The following is a description of a gene set: Any process that stops, prevents, or reduces the frequency, rate or extent of the chemical reactions and pathways involving fatty acids. Human Gene Set: GOBP_NEGATIVE_REGULATION_OF_FATTY_ACID_METABOLIC_PROCESS studied in species Homo sapiens, and this is the list of marker genes: ERLIN2, FMO4, INS, UGT1A1, MIR30C1, APOC3, MIR548P, SLC22A13, UGT1A10, PLIN5, NCOR1, INSIG2, CYP7A1, FMO1, MFSD2A, TRIB3, ETFBKMT, MIR342, ACACB, UGT1A4, MIR185, SOX9, WDTC1, ACADL, MIR132, INSIG1, UBR4, KLHL25, APOC1, UGT1A9, MIR766, MIR33A, UGT1A6, SIRT1, SIRT4, CEACAM1, ANGPTL4, BRCA1, UGT1A3, APPL2, ACADVL, UGT1A8, DGAT2 (diacylglycerol O-acyltransferase 2), FMO2, UGT1A7, MIR204, PIBF1, DCAF5, AKT1, ERLIN1